Given this list of marker genes TGFB2, EIF2AK3, OAZ1, PIMREG, NUDT4, TSFM, GNB1L, SSBP2, ARID5B, TCEAL4, TPT1P8, ABO, ID2, COCH, PRR5, UBE2N, MTARC2, APOL3 (NCBI Gene Id 80833), SSPN, KIAA1614, RALY, INO80B, NOTCH3, SLC12A7, RNGTT, DGKQ, ACTMAP, AGGF1, ERC2-IT1, NT5E, CMAHP, OCLN, CST7, HMGN5, LDHC, SFN, AIMP2, GCLM, CHRNA4, JPT2, MICA, ALKBH1, ADK, MYH7, VGLL4, S100P, TMEM38B, GCHFR, ZNF189, NINL, TMPRSS2, BMP8B, LMO2, SLC4A8, CD247, PES1, SLC35D1, DLL3, CRIP2, DAP, B3GALT4, HKDC1, ZNF480, TFRC, DCTN1 (dynactin subunit 1), SULT1A1, ATP6V1D, TBX2, POFUT2, PTTG2, AIM2 (NCBI Gene Id 9447), XKR8, ZNF574, CFAP45, PRDM4, WEE1, HOPX, KCTD7 (NCBI Gene Id 154881), FANCE, ZNF177, RGS9, MAF, PRKAR2B (NCBI Gene Id 5577), ANKRD55, UBE2NL, ARHGAP26, MYO1F, NUP133 (NCBI Gene Id 55746), FAM131A, LGMN, TRAC, GRAMD1C, SALL1, RPUSD2 (NCBI Gene Id 90415), CETN1, DENND3, STK39, TRMT12, RPLP1, IGHA1, FOXE3, ST6GALNAC2, MOCS1, GPR12, PCOLCE2, TYW1, EOGT, TMPRSS11E, NAALADL1, STK38 (NCBI Gene Id 11329), SSTR5, FAS, ZFP37, PIK3R5, FARS2, BAIAP3, STX11, COL21A1, MAFF (MAF bZIP transcription factor F), NR2F6, CDK17, RHCE, SPP1, PMS2P11 (PMS1 homolog 2, mismatch repair system component pseudogene 11), PIN1P1, PDK4, FUT7, LGALS3, SINHCAF, IL13RA1, TLE1, MICU2, TBC1D4, PIERCE1, ATP2B4, CPLX2, SPTLC1, PPP1R3C, CABP1, SCNM1, RALA, CAMSAP2, GSTK1, PRM2, PCDHGB5, TCHH, MYOC, SMAGP, PSAT1, PODXL, TOX, MIA, VWF, SLC25A12, TST, EGLN2, IGSF1, NIBAN1 (niban apoptosis regulator 1), FAIM, CD86 (NCBI Gene Id 942), ZDHHC6, KLF7, EXT2, ALG9 (ALG9 alpha-1,2-mannosyltransferase), KCNAB2, ITGB1, HOMER3, CRABP1, ECT2, RPRD1A, TUBB2B, RARS1, UCN, EPHA4, PDGFD, FANCG, SLC25A20, TNFRSF10D, POF1B, CCDC88C, MFSD10, TENM1, TREH, WDR7, RRP12, EVI2A, MYCN, CHEK1, HOXC4, GDPD5 (glycerophosphodiester phosphodiesterase domain containing 5), DAAM1, CBR3, DYRK2, HRAS, TRIM62, KRT14, here is a description of the gene set: studied in species Homo sapiens from publication Abbas AR, Baldwin D, Ma Y, Ouyang W, Gurney A, Martin F, Fong S, van Lookeren Campagne M, Godowski P, Williams PM, Chan AC, Clark HF (PMID 15789058) Human Gene Set: GSE22886_IGA_VS_IGM_MEMORY_BCELL_UP Immune cell-specific expression is one indication of the importance of a gene's role in the immune response. In order to identify such patterns, we set out to broadly profile gene expression in a variety of immune cells. Genes up-regulated in comparison of memory IgG IgA B cells versus memory IgM B cells.